The following is a description of a gene set: Any process that modulates the frequency, rate or extent of delayed rectifier potassium channel activity. Mouse Gene Set: GOBP_REGULATION_OF_DELAYED_RECTIFIER_POTASSIUM_CHANNEL_ACTIVITY species: Mus musculus, and this is the list of marker genes: Ank3, Sumo1, Kcne2, Rnf207, Kcnab1, Nppa, Akap6, Akap7, Vamp2, Kcnrg, Kcne1, Kcne3, Kcnq1